Given this list of marker genes MKKS (NCBI Gene Id 8195), GALNT3, BLOC1S6, TTC8, PKDCC, VPS13A, RARG, PLEC, CTC1, CHD7, FOXS1, PRLH, ZFP36L1, TMED2, PPIB (peptidylprolyl isomerase B), NPPC, HTRA2, SLC4A10 (solute carrier family 4 member 10), MFSD8, GHRL, EP300, FOSL2, LGMN, TNS2, SOS1, PLEKHA1, IFT80, LLGL2, ATRX, MBD5, SOD1, FTO (NCBI Gene Id 79068), GRHL2, AAAS (NCBI Gene Id 8086), APBA2, RARA, GPX4, ODAD3, SELENOM, RASAL2, LARGE1, BRINP2, WDTC1, NPR2, STAT5B, HEG1, GDF5, PRICKLE1, SIX3, VIL1, ATRN, DRD2, COA5, GINS3, ARID5B, STAT3, XRCC2, GPD2, HOXA5 (homeobox A5), OTOA (otoancorin), POU3F2, SOCS2, NPY1R, CELA1, SLC25A25, ATF5, AR, FLVCR1, SLITRK1, PEX5, SPTBN4, AFG3L2, ERCC6, PLAG1, CCM2, COMT, STC2, GUCA2B, ZFY, GAREM1, CSF1, SLC6A3, BBS2, GDF15, TARBP2, NIPBL, SLITRK6, TBL1XR1, ADRB1, COL3A1, APBA1 (NCBI Gene Id 320), PPP1R13L, GIGYF2, GNAS, HSF1 (NCBI Gene Id 642255), WDR11, PLS1, GHR, IGF2, RC3H2, WWTR1, G6PC1, RMI1, VPS13B, PIK3CA, EN1, SUV39H1, EXT1, HMGA2, BCL2, CLIC4, GPR21, RAI1, ADRB2, TAL2, ADRB3, PTPN11, SLC1A2, STAT5A, ATN1, NDUFS6, APP, PALB2, BBS4, CREB1, HESX1, ETNK2, CDKN1C, BRINP3, GHRHR, SPTBN2, SMO, ZMPSTE24, SMPD3, STIL (NCBI Gene Id 6491), TAF10, SGPL1, HELT, WDR48, COMP, GAMT, DNAAF3, FXN, IHH, FKBP8, HDAC3 (histone deacetylase 3), SCNN1B, ERCC2, SLC12A5, CACNA2D2, STK40, XPA, GHSR, ERCC1, MTOR, RBBP6, PLAC8 (placenta associated 8), H3-3A, GH1, IGF1, KLF2, ATM, PTCH1, GMNC, TP53, GPAT4, H3-3B, EZR, KAT2A, DIO3, ADARB1, COX10, NOTCH2, GPAM (NCBI Gene Id 57678), MFSD2A, ATP8A2, GHRH, RARB, here is a description of the gene set: The increase in size or mass of an entire multicellular organism, as opposed to cell growth. species: Homo sapiens Human Gene Set: GOBP_MULTICELLULAR_ORGANISM_GROWTH